The following is a description of a gene set: from publication Nakaya HI, Wrammert J, Lee EK, Racioppi L, Marie-Kunze S, Haining WN, Means AR, Kasturi SP, Khan N, Li GM, McCausland M, Kanchan V, Kokko KE, Li S, Elbein R, Mehta AK, Aderem A, Subbarao K, Ahmed R, Pulendran B (PMID 21743478) Human Gene Set: GSE29618_PRE_VS_DAY7_POST_LAIV_FLU_VACCINE_MDC_DN Systems vaccinology has emerged as an interdisciplinary field that combines systems wide measurements and network and predictive modeling applied to vaccinology. Here we used the systems vaccinology approach to study the molecular mechanisms underlying th Genes down-regulated in comparison of myeloid dendritic cells (mDC) from LAIV influenza vaccinee pre-vaccination versus those at day 7 post-vaccination. species: Homo sapiens, and this is the list of marker genes: SLC35A3, MYH4, FOSB (NCBI Gene Id 2354), BCL11A, RPL27, PLPP1, CYP2R1 (cytochrome P450 family 2 subfamily R member 1), TRPC2, EFNA4, PCBD1, IFNA16, NUDT6, PYGB, KCTD17, VWA8 (von Willebrand factor A domain containing 8), SMARCC2, HILPDA, DEXI, ODF1, POLR2J, SOAT2, SIGLEC7, RNF38, ZNF175, NEK9, TPTE, SLC10A3, COX5B, SETMAR, PSMD5, LILRB1, SRR, IFNB1, STAU2, MARCHF1, SUPT20H, IL4R, ALPG, NNT, SCRIB, SPATA20, ZNF518A, H2AC13, LRRC23, ATG13, BPTF, CYP4A22, IFNAR1, KIF16B, ATP8B4, DCLRE1C, PRKCA, MED25, ZNF184, SAP30, CEL, PRPF38B, RFXAP, SACM1L, SEC24A (NCBI Gene Id 10802), PLK3, HSD3B1, TBRG4, ZNF225, OBSL1, FAM216A, ATAD2, SMIM27, RGS10, PIGP, PTCD1, HYAL2, PTER, PRMT3, ADGRA2, CCNK, CYP4F2, SYMPK, RAD52, HNRNPAB, GRAMD4, CFAP20, MFSD12, AK5, GRK2, GOLGA8B, RANGRF, LDB1, TBL1XR1, SRSF7, SCNM1, IFRD1 (NCBI Gene Id 95049), CHMP1B, EHBP1, MRPL15, GYPA, KHSRP, RGS1, SIVA1, PLEKHO1, SLC4A3, EIF4B, MROH7, H2BC5, FNTA, FAM136A, LRIG1, ACADVL, JUN, MYH1, CEP192, DDX49, STK17B, EXOSC5, APBA2, TMX4, TNPO1, BEST1, PDE5A, FLII, FABP6, SYNC, PTPN22, CCN1, EGR3, PDSS1, EHMT2, TMED1, ISYNA1, ZNF480, HEXIM1, KRT1, CTPS2, N4BP1, USP24 (ubiquitin specific peptidase 24), KLF9, TACO1, ST8SIA4, TOX, HIPK2, RHOBTB2, UBE2Q1, GPR107, CCDC82, KLF6, EGR1, ISG20L2, PKD2, NOTCH2, LST1, PRKCI, C6orf120, WASHC4, FRAT1, IDI2-AS1, COL9A3, PLCB3, KIF1B, ZBTB40, MYO7A, RETREG2 (NCBI Gene Id 79137), SPP1, KYAT1, EIF2B5, ASPA, NXPE3, LY86, EIF2B3, ENGASE, AAAS, TEX261, ORC3, CEP43, CSF3R, LRP5L, STX17, ZFP36L2 (ZFP36 ring finger protein like 2), SAP30L-AS1, MT1HL1, NFE2L3, CORO1A, EMCN, RPL10, CCNL2 (NCBI Gene Id 9613), CLTC, PDCD6, NRDC, IRAK1, KLF12, CHD3, DOK2, CIITA, IPO5, DARS2 (aspartyl-tRNA synthetase 2, mitochondrial), ASB7, TBKBP1